Given this list of marker genes STX5, CDKN1B, NEAT1, CTSL, SRRM2 (NCBI Gene Id 51462), OSER1, GARS1, ID2, USP3 (ubiquitin specific peptidase 3), TES, IPO7, GOLGB1, AIMP2, JUND, ZFP36L1, here is a description of the gene set: studied in species Homo sapiens Genes up-regulated in EVSA-T cells (breast cancer) treated with 5 micromolar THC (delta-9-tetrahydrocannabinol) for 8 h. from publication Caffarel MM, Moreno-Bueno G, Cerutti C, Palacios J, Guzman M, Mechta-Grigoriou F, Sanchez C (PMID 18454173) Human Gene Set: CAFFAREL_RESPONSE_TO_THC_8HR_5_UP It has been recently shown that cannabinoids, the active components of marijuana and their derivatives, inhibit cell cycle progression of human breast cancer cells. Here we studied the mechanism of Delta(9)-tetrahydrocannabinol (THC) antiproliferative action in these cells, and show that it involves the modulation of JunD, a member of the AP-1 transcription factor family. THC activates JunD both by upregulating gene expression and by translocating the protein to the nuclear compartment, and these events are accompanied by a decrease in cell proliferation. Of interest, neither JunD activation nor proliferation inhibition was observed in human non-tumour mammary epithelial cells exposed to THC. We confirmed the importance of JunD in THC action by RNA interference and genetic ablation. Thus, in both JunD-silenced human breast cancer cells and JunD knockout mice-derived immortalized fibroblasts, the antiproliferative effect exerted by THC was significantly diminished. Gene array and siRNA experiments support that the cyclin-dependent kinase inhibitor p27 and the tumour suppressor gene testin are candidate JunD targets in cannabinoid action. In addition, our data suggest that the stress-regulated protein p8 participates in THC antiproliferative action in a JunD-independent manner. In summary, this is the first report showing not only that cannabinoids regulate JunD but, more generally, that JunD activation reduces the proliferation of cancer cells, which points to a new target to inhibit breast cancer progression.